Given this list of marker genes EMILIN1, CAT, COL8A1, SLC12A6, TBX2, YAP1, ASCL1, MSX2, ABCA12, BRIP1, MIRLET7B, ADGRB2, NR4A1, EMC10, FOXP2, LEF1, FGF1 (fibroblast growth factor 1), MIR24-1, TSC1, RNF220, AQP1, ANXA1, OTC, MEIS3P1, HMOX1, FUT1, SLIT2, COL6A1, SP100, WNT3A, TBX1, MAN2A1, MDK, PITX2, SLC7A11, AKT3, SOX17, MIR101-1, TGIF1, NFE2L2, ECSCR, MED12, KCNQ1, PKD1, HOXD11, PAX6, EPHA4, GPC3, CASP3, IL6ST, MIR210, COL4A3, EGF, ERRFI1, BCAM, CTSZ, HHEX, JAK1, HOXB3, DLG1, SPINT1, MIR27A, PTPRJ, CCN6, SMAD4, EDN1, ALX4, PRICKLE1, RLN2, GBX2, MIR200C, PROK2, NFIB, NR4A3, MIR505, CDX2, CSF1, MIR145 (microRNA 145), PDGFC, ABL1, GPLD1, ADGRA2, NINJ1, LAMA1, GLUL, CDX1, C2CD3, TGFBI, ZNF304, YWHAZ, CSMD1, SPHK1, PPP3R1, HEG1, ITGB1BP1, ADAMTS9, CD36, RTN4, MMP2, TSPAN18, IL12A (NCBI Gene Id 3592), BSG, BMP4, MIR99B, CRKL, MAPK1 (mitogen-activated protein kinase 1), MIR106B, RPL13A, CDK20, MIR19B1, HNF1B, IL1B, COBL, SMPD3, EGLN1, CCL24, NUS1, MIR30C1, EPHA1, PTK7, MYB, PDPK1, HPSE, NCKAP1, SCG2, EPHB2, ACKR3, RHOJ, DCHS1, PAK4, SRC, GPNMB, SFRP2, LTA4H, CXCL17, AIMP2, EDNRB, MYCN, FZD6, PAX8, VANGL2, COL3A1, SARS1, NUP133, CRIPTO, CXCL8, BMI1, RBPJ, CCL2, TCTN1, AMOT (angiomotin), DLL1, TTC8, ST14, DZIP1L, CSF1R, MYC, TRAF3IP1, PKDCC (protein kinase domain containing, cytoplasmic), XBP1, EFNA1, CD47, NPR2, SPARC, MAGED1, FLT1, NDRG4, HSPA12B, ADAMTS2, CCR3, NRXN3, PTK6, PERP, NPR3, STAB2, ADAMTS12, STOX1, SELENON, MIR206, FOXL1, ARID2, NKX6-3, KIT, AAMP, MIRLET7F1, MIR20B, SASH1, ATF2, MIR185, VASP, PPARG, CBFA2T2, VEGFC, DACT1, TEK, ADAMTS1, HOXD13, WNT2, LRP2, CECR2, TGFBR2, VPS4B, CEACAM1, CD40, RASIP1, WARS2, RALA, KLHL3, MME, RPS7, GPR4, NKX3-1, COL4A1, MIR17HG, AGTR1, EGFR, SP1 (Sp1 transcription factor), MIR939, LEPR, EDA, PTGS2, HS2ST1, MIR132 (microRNA 132), HIPK2, LOXL3, CC2D2A, HES5, ERBB2, CALB1, MIR30B, DVL2, BLOC1S6, SOS1, TMED2, SAV1, PACSIN2, CTNNB1, MICAL2, SLC12A2, AR, CD34, TWIST1, ENG, APOB, PPP1R16B, MKKS, TBX5, FKBP8, MIR149, MCAM, KRIT1, MEOX2, TNNI3, SOX10, GRHL3, FOXC1 (forkhead box C1), ITGA5, TGFB1, CCN3, SOX4, JUN, JCAD, TSC2, PRKD2, FOXF2, JAG1 (NCBI Gene Id 3715), ALX1, SERPINF1, FOXB1, OTULIN, CAV1, APOD, SSBP3 (NCBI Gene Id 55126), TNF (tumor necrosis factor), KDM5B, ID2, B4GALT1, MET, SMAD2, MARCKS, FZD4, HOXA1, CYP1A1 (cytochrome P450 family 1 subfamily A member 1), HMGB1, RB1, TBX18, SOX18 (SRY-box transcription factor 18), CASP8, ROBO1, TFAP2C, ATXN1 (NCBI Gene Id 7912), PKHD1, TLR3, STAB1, KIF18A, VPS52, PIK3C2A, GJC1, FOXN1, WNT11, RAP1A, TIPARP, PAK1, PKD2, KLF2, AGO2, RELA, ANPEP, ABCA3, IL10, MIR200B, APLNR, RSPO2, SPRED1, PKNOX1, HTN1, LZTS2, VAV3, CEMIP2, IFT52, THY1, SRSF6, OVOL2, EGFL8, RXFP1, WDR48, FYN, CDH2, ROBO4, ETV2, WNK4, FGF8, FOXN4, VASH2, FGFR2, HOXA7, APOLD1, MYOCD, NAXE, SOX8, RNF207, RPGRIP1L (RPGRIP1 like), FGF10, ITGB3, MAN1A2, CCM2, CCBE1, HIPK1, PECAM1, CLIC3, ESM1, FZD8 (frizzled class receptor 8), WT1, ETS1, RARG, LCN2, GET1, CALCRL, CHI3L1, NKX2-6, PF4, TNFAIP2, MIR92A1, PHF14, YJEFN3, FMNL3, TBX20, ANGPT4, ZFP36L1 (ZFP36 ring finger protein like 1), UBB, HDAC7, ELK1 (ETS transcription factor ELK1), ITPK1, MIA3, CDX4, SPDEF, CER1, KIF26B, GHRL, ATP7A, MIR29B1, PBX1, LDLR, PRCP, AKT1, HEYL, TMEM215, CITED1, MEF2C, AQP11, APAF1, SCT, PDCL3, LRG1, GATA3, GREB1L, PTPRB, WNT7A, NTRK1, THSD7A, MIR410, MIR378A, GJA5, EVA1A, SLC1A1, IFT172, EP300, HGS, NDNF, YIPF6, TRIM71, ZFPM2, CTHRC1, SOSTDC1, CCN1, VEGFD, PANK2, PROM1, TERT, RASA1, ASB2, CCN2, STK3, LHCGR (luteinizing hormone/choriogonadotropin receptor), MIR640, FASLG, SEMA6A, IRX2, FGF16, NKX3-2, MIR16-1, BCAS3, ZMIZ1, E2F7, NKX2-8, GPR15 (G protein-coupled receptor 15), PDX1, SFRP1, SEMA3E, MIR1224, EDN2, HIF1AN, MIR222, SMAD5, CHD8 (chromodomain helicase DNA binding protein 8), NODAL (NCBI Gene Id 8114), MIR34B, JMJD6 (jumonji domain containing 6, arginine demethylase and lysine hydroxylase), RCN3, CAV3, TULP3, FOXO4, IL17F, GNA13, ARG2, ADGRG6, TIE1, RNH1, TAB1, SPECC1L, HSPB6, PDGFRB, GRN, SMAD1, KAT2A, HOXB7, MIR1298, ASB4, NOS3, EN1, LGR4, HAND1, ITGB8, SDC4, ZIC3, TBC1D20, KLF5, MIR20A, RSPO3, STAT1, THBS2, SERPINE2, PIK3R6, GLMN, HYAL1, SETDB2, COL4A2, AGT, MIR125A, APOH, BMPR1A, GAB1, SYNJ2BP, MINAR2, FGF7, MIR29A, ARL13B, SHC1, GHSR, MYO18B, CUL7, ADM2, IRX3, SPINK5, CITED2, ACVR1, NAGLU, PDGFA, CRLF1, IFT122, CELSR1, EDNRA, SMAD7, MIR34C, ADAM15, CHRD, FOXP1, KRT1, APELA, MEIS3, EPHB3, WASF2, CHRNA7, ZEB1, MYDGF, CREB1, CAMP (NCBI Gene Id 820), MIR217, HTATIP2, ZNF354C, EPB41L5, TEAD2, APOE, ENPEP, C1GALT1, MIR10A, CDC42, UBP1, ANXA2, HECA, CCDC40 (NCBI Gene Id 55036), MIR212, FOXC2, BBS7, CYBB, WARS1, TSPAN12, PGR, TMIGD1, HHIP, EDAR, E2F2, LRP1, DNAAF3, PRKX, WNT7B, EGFL7, ECE1, FOXA1, TMEM201, TGFBR1, BBS5, LOX, MIR130A, ALDH1A2, SERPINE1, TIMELESS, ANGPT1 (NCBI Gene Id 284), CBY1, ARHGAP22, TLR9, PIK3R3, MIR329-1, CTNNBIP1, HIF3A, TGFB2, NRP1, C5AR1, CCL11, FGF18, ADAM12, CSNK2B, BMP5, GATA6, TBX4, NOTO, HLA-G, ANGPTL6, BTG1, ALOX5, COL8A2, GDF2 (growth differentiation factor 2), HDAC9, ISM1, GPX1, PLK2, RECK, PGK1, SMAD3, NKX2-3, ADAM7, SEC24B, CSPG4, SHH, NPY, SRPX2, NTN1, THBS4, MIR424, TP73, TACSTD2, TJP1, HIF1A, LGR5, GZF1, FER, TCAP, NF1, PAX2, EMILIN2, RAMP2, TGFB3, PARVA, COL2A1, FGF6, UNC5B, PDGFRA, KLF4, GRHL2, AMOTL1, MIR138-1, AGTR2, NPNT, HSD11B1, RYR2, BAK1, DEAF1, MIR205, DLC1, IL13, SFRP5, SCAPER, STK4, EPGN, MIRLET7A1, EPAS1, IFT57, ATP5IF1, FLT4, LTBP3, NFIA, SRF, GADD45A, BASP1, TNN, MIR150, ADAMTSL2, PLXNB2, E2F8, FKBP10, SH2D2A, KAT5 (lysine acetyltransferase 5), ADM, SPRY1, EPHB1, NEDD4, BCL2, GPR161, MIR15B, KIF20B, CCR2, RC3H2, ZNF358, PIK3CB, PDCD10, JUP, DAB2IP, MMRN2, AIMP1, WWTR1, ROBO2, CEBPA, AREG, BRCA1, MAP2K5, PML, ID1, WNK1 (NCBI Gene Id 9872), CCDC134, PLXDC1, DDR1, MYLK, INTU, PYY, NR2E1, ING2, ARHGAP35, SLC22A1, ELK3, SEMA4A, ADGRF5, STIM1, PTCH1, PROX1, IFT25, RAMP1, NDP, SHOX2, FOXF1, SALL4, PIK3CD, MIR214, C3, ADGRG1, NUP50, ADIPOR2, MIR29C (microRNA 29c), ADGRB3, IGF1, GTF2I, HRG, WDR83, ADAMTS16, IGFBP7, MIR1908, JMJD8, LRP5, NTRK2, MIR361, ZC3H12A, CHD7, FOXD1, C1orf54, WNT4, RRAS, PAX7, SRPK2, COL15A1, PGF, MIR199A1, GMNC, DVL1, ABCC8, BBS4, HES1, PRKD1 (NCBI Gene Id 5587), S100A7, LIAS, VEGFB, KRAS, SIM1, MIR19A, MEGF8, CRH, DSG2, PERCC1, RIN2, SGCD, FKBPL, CLDN5, SMAD6, MIR22, PRRX1, ESRP2, MIR126, LHX2, SEMA4C, NR2F2, RHOA, BMP7, IHH, TNFRSF12A, MIR26A1, AP3B1, NIPBL, HSPG2, PPP1CA, TNMD, MIR146A, NRXN1, SMO, SIX2, ERAP1, CXCL10, NOX5, NOTCH2, CTSH, ITGA3, THRA, SYK, THBS1, NOTCH4, NRCAM, SIX4, NKIRAS1, COMP, MCIDAS, HESX1, STARD13, MTHFD1L, ANGPTL3, TAL1, TGFA, OR10J5, WNT2B, SHB, EPN1, GDF7, ATP6AP2, MTSS1, EPN2, PLXNA4, CCDC103, ANGPTL4, FN1, SDCCAG8, ZEB2, SOX9, STIL, ACTG1, MIR181B1, RORA, HS6ST1, HOXA11, TMIGD2, SLC31A1, RBPMS2, SIX1, GDF11, MTHFR, LEP, SEMA5A, HOXA3, PTK2B, PRL (NCBI Gene Id 5617), PTPN6, PLOD3, RHOB, CLUAP1, JAM3, PLCD3, TNFSF12, FGFBP1, PRDM1, EFEMP2, MIR34A, NRARP, DLL4 (delta like canonical Notch ligand 4), MIR143, RUNX1, FZD5, TYMP, CIB1, MAP2K2, FOXH1, DNAAF1, WNT6, DCN, DDAH1, MED1, CLIC4 (NCBI Gene Id 25932), TRAF4, EPHA2, PDE3B, KDM2B, SFTPD, SEMA3C (NCBI Gene Id 222200), MIR503, HLX, TMEM38B, RET (ret proto-oncogene), NR3C1, MIR342, DLG5, ACVRL1, TBXA2R, KDR, ACAT1, HAND2, PRKCB, SGPL1, POU3F3, MEIS1, OPTC, TGM2, ANGPT2, RAB3A, ISL1, PRKACA, FUZ, DACT2, LUZP1 (NCBI Gene Id 7798), EFNA3, ADAM8, HS3ST3B1, PODXL, PXDN, FAP, CDH13, IRX1, EPCAM, VASH1, AGR2, CIMAP3, LIPA, LIF, ATXN1L, EPHA7, MIB1, EGR3, OSR1, RGMA, RNF213, PSEN1, MIR296, IL1A, ADTRP, TBX3, HPGD, SLC22A6, SLC39A12, MIR221, GREM1, SMOC2 (SPARC related modular calcium binding 2), CREB3L1, OPA1, CFL1, NKX2-1, HDAC5, CCNO, MMP19, VAV2, PRKACB, RARA, EYA1, CLEC14A, PAXIP1, CEP290, TIGAR, ODAD3, BMPER, EXT1, ITGB1, MIR375, CYP1A2 (NCBI Gene Id 1544), TTBK2, PKM, ROCK1, SPI1, MIRLET7G, NFATC4, MIR199B, MIR21, ITGB6, PTGIS, ITGB2, EHD4, PROK1, TMEM107, CLCN2, MIR494, SULF1, MIR31, PLXND1, MAP2K1, SCRIB, MIR23A, MTHFD1, MTDH, SP3, NKX2-2, JUNB, EMX2, FZD3, ANXA3, NPHP3, FGF9, ODAD4, MIR125B1, DAG1, CRISPLD2, POFUT1, MIR17, MIR193A, GATA2, AMBRA1, MIR30A, AQP2, FERD3L, COL18A1, CCNB1, CDH5, MIR153-1, TMEM59L, NCL (nucleolin), RARB, LAMA5, BAX, F3, MMP12, MIR320A, UMOD, WNT9B, VSTM4, PDGFB (platelet derived growth factor subunit B), SERPINF2, ATP5F1B, MFGE8, ATP2B4, FOLR1, EPHB4 (EPH receptor B4), PCSK5, HOXA5, NRP2, MAPK7, MINAR1, NFATC3, RCBTB2, BAG6, KLK3, RARRES2 (NCBI Gene Id 5919), GATA4, PRKCA, PLCG1, HEY2, CIC, SAT1, LHX3, IFT140, NPPB, ADGRB1, REC8, FOXE1, THRB, TP63, ADA, EFNB2, HEY1, RDH10, BMPR2, SKI, NOTCH1, MIR137, PTK2, PDCD6, PHEX (NCBI Gene Id 5251), HMGA2, NPRL3 (NCBI Gene Id 8131, NPR3 like, GATOR1 complex subunit), MESP1, AMOTL2, NPR1, HMGCS2, SIM2, WDR19, STAT3, HSPB1, IL6, SALL1, WNT5A, TRAF6, LOXL2, MIR10B, MAPK3, MOSMO, CLDN18, ITGAV, WNT1, PDPN (NCBI Gene Id 29912), TCF21, ESR1, ETV5, SPRY2, NOG, PHACTR4, MIR30E (NCBI Gene Id 407034), ACVR2B, CMA1, STK40, CLMP, STRA6, EIF2AK3, NAA15, HOXA13, EREG, BCL2L11, MIR1-1, DPPA4, CNMD, VDR, IGFBP5, INHBB, MMP14, SUFU (NCBI Gene Id 51684), ASXL1 (NCBI Gene Id 23393), ATOH8, CX3CR1, MIR27B, TMEM100, NKIRAS2, GDNF, LBX1, ROCK2, RBM15, S1PR1, HK2, AHI1, NPPC (NCBI Gene Id 4880), CD24, AGGF1, GLI2, SIRT6, CD93, AKR1B1, C3AR1 (complement C3a receptor 1), BCL10, FGF2, CX3CL1, FOXJ2, CARD10, ILK, CXCL13, GLI1, CXCR3, MECP2, TFAP2B, ITGAX, ECM1, NKX2-5, MIR451A, CELA1, GATA5, ANG (NCBI Gene Id 283), HOPX, SLC23A1, LHX1, PIK3CG, CYP1B1, GSC (NCBI Gene Id 2927), GLI3, TNFAIP3, NGFR, RBBP9, RAPGEF3, MIR483, NOX1, RBP4, MIR885 (NCBI Gene Id 100126334), SPATA2, IL18, HOXB13 (NCBI Gene Id 10481), SREBF1, HAS2, MYH9, MICALL1, RAPGEF2, ITGA2B, AGO1, HIKESHI, ASS1, BTRC, CASR, MIR377, PHB2, SLC4A2, LMO4, BMP2, NOTCH3, TAFA5, SOX11, MIR487B, HS3ST3A1, MYO1E, FGFR1, PHGDH, MIR492, RGCC, MIXL1, CCDC39, S100A1, FOSL2, MMRN1, SIRT1, IL12B, CPS1, PIK3CA, MIR196A1, MAPK14, BRD2, WDPCP, FOXJ1, MKS1, MIR15A, MIR2355, ARHGAP24, CTNND1, PTPRM, PFN1, EMP2, VEGFA, PLXNA2, MIR18A, MIR495, APLN, ATRX, MIR497, TNC, CD160, FBN1, CCKBR (cholecystokinin B receptor, NCBI Gene Id 887), FBLN5, TBC1D32, SPINT2, VEZF1, QKI, TGFBR3, here is a description of the gene set: The process whose specific outcome is the progression of a tube over time, from its initial formation to a mature structure. Epithelial and endothelial tubes transport gases, liquids and cells from one site to another and form the basic structure of many organs and tissues including lung and trachea, kidney, the mammary gland, the vascular system and the gastrointestinal and urinary-genital tracts. studied in species Homo sapiens Human Gene Set: GOBP_TUBE_DEVELOPMENT